The following is a description of a gene set: Abnormal temper tantrums Temper tantrums are brief episodes of extreme, unpleasant, and sometimes aggressive behaviors in response to frustration or anger, which are a normal part of development in toddlers. Temper tantrums that occur more frequently in a given time and/or are more severe in symptomatology and/or longer in duration and/or inappropriate for the given age compared to a temper tantrum that naturally occurs as a part of the developmental process are classified as abnormal temper tantrums. species: Homo sapiens Human Gene Set: HP_ABNORMAL_TEMPER_TANTRUMS, and this is the list of marker genes: SRCAP, TAOK1, SCN8A, IQSEC2 (NCBI Gene Id 4382), CSNK2A1, WARS2, ADNP, DEAF1, SETBP1, OCA2, CNTNAP2, CTCF, MYT1L, NDN, GBA1, OFD1, ACBD6, RAI1, FMR1, TLK2, PPP2R5D, DPF2, KAT5, CTNNB1, PACS1, SNRPN, TACO1, USP7, FOXP2, GNAI1, MAGEL2, SATB2, FLII, SIM1, ARPC4 (actin related protein 2/3 complex subunit 4), CLCN3 (chloride voltage-gated channel 3), TUBB2B, RSRC1